Given this list of marker genes IL2RA, SLC16A2, ZBTB44 (zinc finger and BTB domain containing 44), TMEM69, CLTRN, ITM2B, SVIL, TUB, AKAP13, SH3PXD2A, COL24A1, SLC25A15, MFSD6, ABL2, SCAMP4, ITGB8, NEURL1, SYT3, PAN3, COL1A1, ABHD14A, COL25A1, ST8SIA4, SLC7A11, CHST10, BAG3, GIGYF2, HTR2C, ZNF514, PTPN23, DENND1B, HIPK2, ASB4, VAPB (NCBI Gene Id 9217), TRAPPC8, FAM117A, CLSPN, FRS2, MSI2, NEXMIF, WWC3, SLC38A2, ZNF701, PCDH15, SFXN1, C12orf76, EFS, AFG2B (AFG2 AAA ATPase homolog B), LMO4, PSME4, AFF1, ARHGAP26, MAPK7, GABARAPL1, IGFBP5, MAP3K7, RPP30, GOLM1, FBXO46, BRD2, GNL3, ATP6V1A, RAB11FIP1, RECQL5, AFG1L, SC5D, SECISBP2L, MGP, PLPBP, EPB41L4A, CACHD1, USP24, TTPA, ASAP3, MYO5A, ETV6 (ETS variant transcription factor 6), STOX2 (storkhead box 2), ZNF583, UNC5A, GLI3 (NCBI Gene Id 2737), SYNCRIP, FSCN1, MEX3C, TP53RK, SEMA5A, SCUBE2 (NCBI Gene Id 57758), UBE2E2, TMEM178B, ZBTB41, DIP2B, BAAT (NCBI Gene Id 570), SIX4, DSG1, SRD5A1, TMEM242 (NCBI Gene Id 729515), EIF2AK3, SMNDC1, RND2, CACNA1A, AKAP6 (NCBI Gene Id 9472), HOXA5, NFATC1, UBE2E3, NPR3, LRP12, FOSL2, SELL, AHCYL1, TSHR, FNDC5, COMMD2 (COMM domain containing 2), EME1, MEDAG, DISC1, NEK5, TGM2, CCDC110, NFXL1, B9D1 (B9 domain containing 1), SEC14L4, INSYN2A, KRT80, CA8, PTPN4, SYT10 (synaptotagmin 10), ETV3, VAX1, ABHD17B, VASH1, TAF12, MRTFB, CRELD1, TET1, RNF6, SHISA7, TM2D2, PSEN1, SINHCAF, RBM24, SRSF11 (serine and arginine rich splicing factor 11), FTSJ1, MYO6, USP40, HTR2B, DEGS1, KRAS, TBL1XR1, SLC39A11, INO80D, NECAP1, STAC, PPM1E, LRBA, ALDH1L2, KIF3B, PACRGL, HTR3A, ZWILCH, CDC42BPA, CBFB, EXOC6B, ATP10A, ELMOD1, ERC1, EPM2AIP1 (EPM2A interacting protein 1), GDF10, UBXN2B, CMPK1, THRB, FGF1, TTPAL, PHF6, ZNF182, GPR15, NSD2, NUAK2, CIR1, FGF9, TAF1L (TATA-box binding protein associated factor 1 like), ARFGAP3, CPB2, WASF3, FAR1, KAT6A, PC, MLLT10, MYBL2, GXYLT1, KCNN3, STRN3, CPD, MAB21L1, DCLK1, FADS6, PGLYRP4, FNDC3B, ADD3, PDIA6, SLC30A8, SLC4A8 (NCBI Gene Id 9498), RASGRF2, IL16, COL5A3, MOGS, here is a description of the gene set: from publication Chen Y, Wang X (PMID 31504780) studied in species Homo sapiens Genes predicted to be targets of miRBase v22 microRNA hsa-miR-143-3p, hsa-miR-4770 in miRDB v6.0 with MirTarget v4 prediction scores > 80 (high confidence targets). Human Gene Set: MIR143_3P_MIR4770